Given this list of marker genes NSMCE2, HBG2, RPS17, BLM, HNF4A, HBA1, RPS27, ALMS1, KLF1, RPL27, RPS19, PRPS1, NARS2, DNAJC3, LMNA, RPL18, HBA2, BLK, PAX4, RPL26, TSR2, SRP54, RPL31, KCNJ11, RPL5, KLF11, SLC30A7 (NCBI Gene Id 148867), GCK, WRN, RPL8, ABCC8, ZBTB7A, MPL (MPL proto-oncogene, thrombopoietin receptor), CELA2A, NEUROD1 (neuronal differentiation 1), RPL35, RPS28, BSCL2, CYB5R3, YIPF5, SLC5A2, GATA1, MTX2, GTF2E2, HBG1, INS, THPO, PLAAT3, RPL15, HNF1A, RPS7, TRMT5, RPL11, HBD, HBB, RPS20, CYB5A, DNAJC21, RPS24, SBDS, RPL35A, RPS26, MDM4, BCL11A, HGD, RPS10, RPL9, EPOR, RPS29, APPL1, PDX1, HEATR3, RPS15A, CEL, ADA2, DMXL2, ATRX, here is a description of the gene set: Anomaly in the level or the function of hemoglobin, the oxygen-carrying protein of erythrocytes. Abnormal hemoglobin species: Homo sapiens Human Gene Set: HP_ABNORMAL_HEMOGLOBIN